Given this list of marker genes C330008A17Rik, Gm29417, Gm38666, Hbegf, Gm36858, Snora74a, Pcdha3, Cxxc5, Gm10545, Matr3, Pcdha4, Tmco6, Spata24, Gm36315, Maskbp3, Pcdha5, Eif4ebp3, Pcdhac1, Zmat2, Slc4a9, Prob1, Sra1, Mzb1, Apbb3, Cystm1, Slc23a1, Snhg4, Pcdha8 (NCBI Gene Id 353235), Hars1, Pfdn1, Nrg2, Slc35a4, Igip, Cd14, Dnd1, Pcdha1, Pcdha9, Paip2, Hars2, Ndufa2, Gm5239, Pcdha12, Ube2d2a (NCBI Gene Id 80608), Pcdha7, Gm19035, Ecscr, E230025N22Rik (Riken cDNA E230025N22 gene), Pcdha10, Pura, Mir1949, Sil1, Gm6756, Gm6542 (NCBI Gene Id 670627), Pcdha6, Dnajc18, Pcdha4b, Smim33, 4930471G03Rik, Gm16490, Gm18150, Pcdha2, Wdr55, Pcdha11, Sting1, Psd2, Ankhd1, Ik, here is a description of the gene set: species: Mus musculus Mouse Gene Set: chr18B2